The following is a description of a gene set: Any process that results in a change in state or activity of a cell or an organism (in terms of movement, secretion, enzyme production, gene expression, etc.) as a result of a stimulus arising within the organism. studied in species Homo sapiens Human Gene Set: GOBP_RESPONSE_TO_ENDOGENOUS_STIMULUS, and this is the list of marker genes: EEF2, CHRD, FGF6, GCLC, PLCG1, NDP, RB1, NPC1, CEBPA, UMODL1, ANG, GPLD1, LEPROTL1, FOXP1, BSG, FUT7, ABL1, GFRA1, DTYMK, RAP1A, SLC26A5, ADIPOR2, ACTA2, FGF17, PRKCQ, GHRHR, PKM, PTGFR, ZNF703, FRS2, SPART, FSTL5, FLRT1, LPL, XBP1, CYP11B1, RHOQ, NUDC, FASLG, RXFP1, BAIAP2, CDKN2B, TNFSF4, TMPRSS6, CSN1S1, BDNF, THRA, FGF3, EME1, SPRY3, CXCL12, GPX1, EMD, BCL9L, SCGB2A2, MIR302B, MIR342, EMILIN1, RUNX3, ATP5F1A, TACR1, SDCBP, PTF1A, CD44, FYN, PPARG, PML, DHRS3, XIAP, VWA2, HMGB1, GRIA1, CCR7, SYAP1, LHCGR, ADCY6 (NCBI Gene Id 23320), HMGA2, TMEM100, GLG1, GLP2R, FIBP, FAM89B, WNT1, TIGAR, FURIN, LTA4H, VEGFD, APOE, MYO5A, SOX2, CREB3L1, WNT7B, HIF1A, ABCC9, RCAN1, GRB14 (NCBI Gene Id 2888), ADCY8, GPER1, SMURF2, PRAME, CITED2, DOK5, LRRC32, MIR503, FGF20, MIR379, EGFR, FLT4, JUN, GBA1, PAK1, COMP, LIMS1, ROBO2, SP100, ADTRP, DEFA3, MED1, SNRNP70, MIR212, VEGFB, ACSBG1, AHSG, SLC2A10, CHRDL1, SPI1, RBM14, INTS9, ITGA2, SCN11A (NCBI Gene Id 337933), REST, UCN2, GCGR, DAND5, RAMP3, MIR143, SOCS3, RWDD1, EPM2AIP1, PROKR2, PTPN11, CDH5, AGRP, BMP5, SPINT1, INS, SUDS3, ADAMTS7, CSH1, PENK, THRB, CBL, IL1RN, AANAT, RGMA, OFD1, EDNRA, NR2F2, RNF111, PIP4K2A, ALPL, NCOA2, IDE (NCBI Gene Id 3416), RASL11B, ZEB2, CLDN4, KDM3A, CFL1, NR1H4, CALCR, EIF6, MIR4632, GDF9, ING1, KCNC1, FERMT1, MIR210, ILK, CCL19, WNT10B, ATF2, BCAR3, PTPRE, ADIPOQ, MIR498, CEP57, CD109, NFIA, ALAS1, NEFL, MIR424, GIT1, CSNK1E, KDM5B, FSTL1, TNC, ATP2B1, RAB31, OTC, ABCA2, ZDHHC17, INHBB, SAFB2, PITX3, MIR20A, GPR82, TRIM33, CRH, TPR, ASCL1, CTSH, SKI, TSC22D1, SH2B2 (NCBI Gene Id 10603), PCSK9, HMGB2, INPP5K, SLC4A7, RAP1GDS1, PDK4, TRIM71, PRL, CREBBP, HYAL2, HTRA4, LRG1, LRIT3, ANGPT1, BBS4, GNRH1, ZFHX3, TMF1, DDIT4, BMP4, ARRB2, SLIT2, FBP1, CCBE1, MIR10A, CSTF2, BMP7, MIR130A, AVPR1B, IQGAP1, F7, TGFB2, PRMT1, NRP2, FEZ1, UCN3, EXT2 (NCBI Gene Id 2132), DAB2, HDAC6, NR3C1, SLX4, MYOG, MIR1-1, FABP3, CORO1B, TRIM72 (tripartite motif containing 72), CEACAM1, PRLH, BCHE, BMP2, MAPK3, S100B, PIK3CA, RBM4, RBFOX2, AKT1, PIM1, GREB1L, TBX1 (NCBI Gene Id 7413), POSTN, CRHR1, VEPH1, TBC1D7, PPARA, CCNA2, SAP130, BECN1, SOCS7, WT1, SCAP, BRMS1L, MIR26A1, SLC5A5, SKOR2, VWC2, UBA5, AVPR1A, APP, IRS4, PADI2, JUNB, CCN1, HCRTR1, CACNA1H, SCNN1B, CELA2A, ARF6 (NCBI Gene Id 63379), MIR493, YWHAG, PIK3CD, FOXC1, GHR, GDF10, CYP11A1, HSP90AA1, KMT2A, PTGDR, OXT, CTNNA1, HGS, GIPC1, PHIP, NGLY1, HCN2, REG1B, IL22 (NCBI Gene Id 57328), CLOCK, MIR140, NR2C1, MIR204, GSK3A, PID1, MSX1, MIR9-1, HDAC2, PAK2, CREB1, SLC2A1, NPTN, MIR181A2, MIR142, ADGRG1, TBX20, MKKS (NCBI Gene Id 8195), PMEPA1, NR5A1, MSX2, ECHDC3, RARRES2, UGCG, FUZ, EGLN2, MIR372, GREM1, LCN2, LTBP3, MYC, GATA3, TGFBRAP1, NR4A3, ATP1A3, CLDN5, STAT5B, TMEM119, OVOL2, PTGER4, PHB1 (prohibitin 1), NRP1, KIDINS220, ACVR2A, ZNF366, CYP11B2, RAPGEF1, PIK3R2, GHRL, MIR10B, FKBP1C, SOX30 (SRY-box transcription factor 30), BMI1, STXBP4, FSHR, HDAC9, NOTCH2, MMP14, HPGD, SMAD4, CES1, NLK, TIMP2 (NCBI Gene Id 7077), OTX2, NGF, GABRB1, EZH2, NCK1 (NCK adaptor protein 1), PPARD, MIR497, NCOA5, ANXA1, SOS1, NPPA, DMD, ARID4B, SMC1A, ETV2, BMPR1A, USP9Y, DNAAF4, NR1H2, MT1G, SSTR2, RNF6, PRKCD, HSPA1A, FKBP8, NKX6-1, FNDC4, SFRP1, SPRY1, HAS1, RBX1, FUT8, TWSG1, NPNT, AREG, AKR1C1, ACVR1B, EXT1, CYBA, MIR103A1, MIR573, FST, RBP4, SOCS1, ROCK2, NFKBIZ, MIR23A, IGFBP7, ZNF8, SMAD1, SNCA, ENG, NCOA6, PARK7, CLDN1, EIF4EBP2, KRAS (KRAS proto-oncogene, GTPase), TIMP3, SULF2, PELO, ACVR1C, FLCN, PLA2G2A, USF1, GCLM, APOA1 (apolipoprotein A1), SOCS2, POR, NOS1, HCRTR2, FSHB, UBE2L3, ADAM17, RPS6KB2, IL23R (NCBI Gene Id 94006), NEDD4, PHOX2B, KLF15, NR2E3, FGF12, STMN2, CFLAR, ADIPOR1, EIF4A3, SORBS1, YY1, CYP27B1 (NCBI Gene Id 5135), EEF2K, STAT5A, CALR, DDR2, MIR27A, MIR106A, PDCD7, TLR6, CAT, DYNC1LI2 (dynein cytoplasmic 1 light intermediate chain 2), SREBF1, VWC2L, OGT, KDM1A, HRG, ZEB1, CUL3, ABCB1, CBX3, CRHBP, GATA5, NTRK3, PPM1A, EPRS1, HSPA8, LHX1, SHCBP1, PTPRJ, FGF9, BCAR1, MIR15A, LGMN, CRY1, LEMD3, GLP1R, ABCA3, SSTR1, JUND, ITGB6, MIR93, SLIT3, ANGPTL3, EDNRB, KMT2D, MUS81, APC (NCBI Gene Id 324), SSTR5, SLC2A4, LPIN2, HFE, TRIB3, FSTL3, MT-ND3 (NCBI Gene Id 4537), AKR1C2, MIR1298, CTSB, FAT1, ACVR2B, MIR520C, PLK5, UCN, TICAM1, LDLRAD4, REG3G, IL6, BRD8, GDF6, MIR208A, MIR758, FBH1, CXCL8, ALAD, FBXW8, YWHAH, PRKDC, GPR155, RAF1, TOMM70, FECH, MIRLET7B, PAQR7, CASK, NTF3, RERG, KAT2B, AHCYL1, PLN, ACR, ADRA1A, ITGB8, DLL1, GATA6, TMEM53, HOXA13, PLCB1, MXRA5, PRLR, DDRGK1, SOX11, BGLAP (bone gamma-carboxyglutamate protein), REG3A, SMAD5-AS1, FGF18, RAMP2, SLC2A8, SULF1, GALNT3, EHD4, LONP1, MC4R, STC2, SHC1, ARPC3, PTH, MBD5, ZFYVE9, STAT1, LATS2, EHD1, IL10, MIR98, GNAQ, DSG2, NPFFR2, PRKCI (NCBI Gene Id 5584), USP8, SMYD3 (NCBI Gene Id 81838), NCOA1, PER1, MIR100, CAV2, RARB, VASN, ERFE (NCBI Gene Id 151176), FLT1, HGF, FGF16, LEP, MDM2, TRIM24, RPS6KB1 (ribosomal protein S6 kinase B1), IDH1, NR1D2, PRKAA2, CCDC62, NEO1, FGF4, VDR, SHQ1, MIR29B1, RGCC, DDX5, UFM1, MIR339, GDF5, DAXX, QRFPR, LDLR, MYOCD, ASS1, TET1, FKRP, SRD5A1, EREG, URI1, CALCOCO1, NPAS4, AVPR2, SLC25A33, WDTC1, BTG2, NTF4, MIR199B, CTNNB1, OPRD1, CYFIP2, FAM20C, NR3C2, PAX9, VGF, HADHA, BLVRB, PAX8, ERBB2, TGFBR3, ZFP36L1, ZPR1, CPNE3, PXN, NOG, UBE2O, CAV1, UCP1, COL1A1, EIF2B1, CRY2, TCF7L2 (NCBI Gene Id 6934), IRS2, ANKRD13C, TRIM68, CRKL, MIR92A1, FLT3, ELAPOR2, UFSP2, TIMP4 (NCBI Gene Id 7079), PRKD2, PTPN2, PTPN1, POU5F1, MAP2K3, MMP2, AGTR1, NRROS, CLDN18 (NCBI Gene Id 51208), BCL9 (BCL9 transcription coactivator), NKX3-1, ITGB5, FGF5, CTSS, ABCA1, RAMP1, SRF, APAF1, NUS1, SCGB2A1, IL12B, ABCC8, TNF, INSRR, FKBP1A, FOXC2, BMP10, SOX5, SORL1, PNPLA3, PDE2A, ACACA, CD2AP, G6PC1 (glucose-6-phosphatase catalytic subunit 1), MAP2K1, HHEX, TRIM25, CNOT1, RXRA, FLRT2, USP15 (ubiquitin specific peptidase 15), SOX6, STK16, MIR199A1, TSPAN32, ZDHHC16, MAP2K5 (NCBI Gene Id 5607), CD24, FGF7 (NCBI Gene Id 82955), SRD5A2, NDEL1, EPHA8, HIVEP1, ZNF592, GH1, ASPN, RAN, MSTN, CDO1, PRKCG, NBL1, APPL1, PTPRU, TGIF1, SMAD6, IGFBP1, PHEX, FMOD, CCN2, ELK1, IL4, WFIKKN2, ATP1A2, CSRP3, SPRY2, TOB1, APPL2, RAP1GAP, IGF1R (NCBI Gene Id 51049), GNRHR2, HSF1, TGFB1, CTSL, RAB10, AGT (NCBI Gene Id 183), AGTR2, LRP6, ERN1, RAPGEF2, CXCL13, PTP4A3, PDGFRB, TADA3, CER1, KCNJ8, DLX1, DSTYK, TGFB3, PRCP, GPC1, TSC1, GTF2H1, PBLD, PROX1, ITGB1, RDX, VIL1, DLX3, TNXB, PDGFD, SNX5, IBSP, ASH2L, EDN1, PRMT2, AKR1C4, GRB2, LUM, FGF10, RAB35, PNPT1, DNAI1, MIR302A, SCNN1G, LANCL2, FERMT2 (FERM domain containing kindlin 2), GKAP1, SCX, GNAI1, SAP30, APLN, CGB3, PPP3CA, RELA, TCF12, STAT2, PTPRC, OXTR, SKOR1, NFE2L2, NKX2-1 (NK2 homeobox 1), VPS18 (VPS18 core subunit of CORVET and HOPS complexes), ZBED3, ERO1A, DENND4C, CIB1, BPTF, C2CD5, STC1, CYP24A1, AR, SOS2, CSF2RA, RXFP2 (NCBI Gene Id 122042), EPN2, IER2, GALP, NCOA3, SAP30L, SGCB, UBE2D1, CRHR2, ITGB2, ITGA3, MIR296, FGFBP3, HSPA1B, FHL2, RNF14, AKT2, PTK2, YAP1, PRDM14, FOXO4 (forkhead box O4), DDX17, VSTM2A, CITED4, TNFRSF11A, ZNF536, TMEM108, HTRA2, VPS13C, DUSP3, KDM4C, ASIP, OR51E2, SRC, GPI, KCNC2 (NCBI Gene Id 3747), NODAL, ARK2C, HIPK2, SLC34A2, SLC34A1, SP7 (Sp7 transcription factor), MIR361, TFAP4, ZFP36L2, PSG9, KCNQ1, CPEB2, TRIP4, ADISSP (NCBI Gene Id 54976), MIR195, HRAS, CTSD, NRXN1, SOST, SOX9, EGR1, DEFA1, JCAD, CCL21 (NCBI Gene Id 6366), MIR376C, GRB7, SLC27A1, DAB2IP, MEN1, TAC1, PCK2, PDGFB (NCBI Gene Id 5155), STEAP2, GPR22, SPRED2, FGF1, EEF1A1, MIR30B, SPRED3, TGFB1I1, HSPB1 (heat shock protein family B (small) member 1), ARPC1B, MIRLET7F1, TBC1D4, HTRA1, LEF1, MEF2C, CSH2, SCNN1D, INSR, WNT10A, GSTP1, BCAS3, PDE3B, UBE3A, EPB41L5, CTBP2, MIR323A, GRB10, FGF2, DUSP22, FGB, POU4F2, KHK, EIF2B3, GCNT1, GLB1, WFIKKN1, FBXL15, MIR373, CDC6, NFKB1, FOSL2, NOS2, ACVR1, MYO1C, RXRB, PPP2R5B, ZYX, LHB, JAK1, CD68, SFRP2, SKP2, NCL, FGFR1, MARS1, SFRP4 (NCBI Gene Id 6424), SEMA6A, FLRT3, CAV3, MYOD1, PDPK1, TSHR (NCBI Gene Id 7253), MEGF8, BLOC1S6 (biogenesis of lysosomal organelles complex 1 subunit 6), TAT, SNAI2, ESR2, ACTN4, MTCL2, HYAL1, BAMBI, NR5A2, GAS6, KNSTRN, AGTRAP, LRP5, OSTN, LTBP2, PDK2, ESRRA, IFT80, MIR196A1, FRS3, MIR490, DAG1, ARNT, NREP, SCGB1A1, COL1A2, GPR173, HES5, WNT5A, PROKR1, ADRA2A, SYK, MGARP, MYD88, TSKU, SOCS5, NR1H3, PIN1, EIF2B5, ACE, CHRDL2 (chordin like 2), NCOA4, SMARCC1, SIK2, UBR5, ESRRB, NOS3, SLC26A6, SELENOS (selenoprotein S), CNOT9, P2RY6, CRIPTO, TAF1, TRARG1, PPP1R9B, NTRK1, SLC27A4, LOX, MIR101-1, BRMS1, HAS2, PALS1, PIK3R3, LATS1, SHOC2, TMEM107, GNAS, AXIN1, SPRED1, BMAL1, SRSF4, PELP1, ZBTB7A, NDN, KAT2A, POMC, SHISA2, ERRFI1, AKAP8, CASR, PRKD1, CORO1A, MIR19B1, TCF21, BMPR2, DLL4, DKK1, GAB1, HIF1AN, ALDH1A2, MEIS2, ZDHHC7, LRP2, DUSP6, ERBB4, PLA2G1B, KLF2, MAPK7, SGK1, INHBA, ADAM9 (ADAM metallopeptidase domain 9), CPEB1, ACAT1, PIAS2, NR4A1, RUNX2, FGFRL1, PIP4K2B, AKT1S1, AKR1C3, SREBF2, RACK1, MAP1B, DSG1, CARD9, FER, GPHB5, CHUK, RARG, NSMF, SLC39A14, TRIM63, SOSTDC1, GCG, HADH, CCL2, BMP6, ID1, IGF2, LMO3, NGFR, PKD1L1, TGFBR3L, PRKCZ, FFAR3, LYN, RBPJ (NCBI Gene Id 51580), RHOXF1, MEAK7, RAB14, PDGFRA, KDM5D, SMAD3, NTRK2, ACTN2, EPO, FUT1, WBP2, GNB1, IL1B (NCBI Gene Id 3553), PKLR, SAFB, UFL1, STRAP, MT3, RXRG (NCBI Gene Id 6258), DNM3OS, GSK3B, FOXO1, MTSS2, IGFBP5, LEPR, CRIM1, ACVRL1, CRB2, MAPKAPK2, MIR4286, STRN3, MDK, SLC24A4, FBN2, MIR19A, PDE8A, EP300 (NCBI Gene Id 2033), RBBP4, OCSTAMP, GCK (NCBI Gene Id 2645), PKD2, ARID5A, GNG2, LCN8, GOT1 (NCBI Gene Id 2805), SPINT2, CASP3, USO1, ISL1, PTPRK, PDX1, INSIG2, EIF2B2 (NCBI Gene Id 8892), SPG21, FGF14, TMEM204, CCND1 (NCBI Gene Id 893), AIFM1, MIR125B1, RAB8A, RAC1, FBN1, ING2, INPPL1, MIA3, CAB39, CDH3, BCL2, ZNF106, CD63, FGF23, SNX6, TFF1, ETNPPL, KRT19, ESRRG, WNT4, SPP1, CYC1, ASXL1, NUMA1, OXCT1, PHB2, SINHCAF, GPRIN3, KANK2, FGF22, MT-CYB, SIN3A, CD9, HSD11B2, CYP26C1, ROCK1, DDIT3, JAK2, XCL1, ZNF423, CNOT2, BBS2, STUB1, TSPO, MIR1271, FOS, USP9X, FAM114A1, ZFYVE27, SMAD9, FAM107A, HCLS1, SOX10, GAL, FGF8, SKIL, DHCR24 (24-dehydrocholesterol reductase), ZMIZ2, ADAMTS3, NOTCH1, GDF7, RETN, MMRN1, FCER1G, EPHA2, LRP8, GNRHR, PLPP1, MTOR, MIR302C, ACAP2, MAPK14, PTPN12, GHSR, HEYL, PDCD4, MTMR4, PCSK6, VAMP2, CSNK2B, HHIP, SCNN1A, ABHD2, SNX25, PKN1, MIR885, HDAC5, CYP26A1, MAP3K7, NKX2-2, KLB, EGR3, NDST1, KCP, NONO, SNW1, ATP2B4, TWF2, FOSB, CHST11, UCP3, HJV, PTGER1, ZNF764, ITGA8, GPR150, MIR329-1, CILP, CGA, AGL, TNS2, ME1, FGFR4, CPN1, GATA4, LEPROT (NCBI Gene Id 83080), HAP1, FOXA1, MIRLET7A1, FZD1, TOP1, NDNF, PIP4K2C, FNTA, SH3GL2, CACNA2D3, CSHL1, MN1, LPXN, E2F1, MZB1, SMPD3, SSTR3, PRDM16, SFR1, MME, ADAMTS12, FGF21, CREBRF, EIF2B4, SP1, STK39, MIR107, OTOP1 (NCBI Gene Id 133060), TRIM16, CAPN10, SMAD5, KBTBD2, SPHK1, OPRK1, DOCK3, TFPI, REG1A, CD38, GDF2, CPS1, TIMP1, DEFA1B, RANGAP1, COL4A2, BMPR1B, GAREM1, FGFBP1, CRK, DKK3, NR0B1, CHURC1, PIK3R1, FOXH1, CYP26B1 (NCBI Gene Id 56603), CADM4, CUL7, GDF3, PRKCB (NCBI Gene Id 5579), NR2E1, BAG4, HNRNPU, CA2, PRKN, DUSP1, WNT7A (Wnt family member 7A), ADAMTSL2, IGF1, PDCD5, ZFP36, ESR1, REN, SERPINB9, KDR, STXBP3, DDX54, MAPT, IL17F (interleukin 17F), BCL2L11 (NCBI Gene Id 150819), EFNA5, TRERF1, HSP90AB1, ACOD1, P2RY1, CD36, LEFTY1, SRSF5, ZNF451, NPFFR1, TP63, MAPKAP1, PRKCE, GCNT2, TXNIP, FGF19, RGMB, MIR183, THBS1, SLC22A12, RHOA, PTGER2, PTGDS, PRKAA1, IL12A, PDE3A, MMRN2 (NCBI Gene Id 79812), VPS11, BTG1, ENPP1 (ectonucleotide pyrophosphatase/phosphodiesterase 1), PTGDR2, TFAP2B, MIR145 (NCBI Gene Id 406937), PGF (placental growth factor), AMHR2, ONECUT2, C1QTNF12, MIR17, NR1D1, YES1, NUCKS1, HPN, GPR83, VEGFA, TGFBR1, MIR200C, CYP7B1, SORT1 (sortilin 1), HDAC1, CARM1, CTDSPL2, SCUBE3, WNT2, MAS1, PCNA, SLC30A10, PCK1, GKN2, CITED1, IGFBP2, CST11, FZD4 (NCBI Gene Id 8322), SLC39A5, STAT3, KLF9, AQP1, TBX2, NCOR2, KL, ITGB1BP1, MIR27B, NPR2, FGFR2, TREM2, PEG10, CDK12, LTBP1, FAM83G, SMURF1, ONECUT1, EIF4E, AP3S1, GDF15 (NCBI Gene Id 9518), GATA1, STAT6, MIR149, RIPK1, STAT4, OSBPL8, RAB13, ANGPT2, UPRT, PRKACA (NCBI Gene Id 5566), SPRY4, MIR1224, ACSL1, RARA, FOXO3, COL6A1, LCAT, MICOS10-NBL1, SH3RF1, KLF4, MIR15B, SIRT1, FBXW7-AS1, CALCA, VCAM1, GAS1 (growth arrest specific 1), RHOD, FBXO32, RPS6, CAMK2A, METTL21C, SLC12A3, MIR135A1, EID2, CDKN1C, ZMIZ1, GH2, USP26, INSIG1, LTBP4, PAQR8, COL3A1, PPP5C, FSTL4, UCP2, SLC10A1 (NCBI Gene Id 6554), HTRA3, PRKAR1A, TRPV4, COMT, ARSB, MIR146A, UBE2D3, MIR564 (microRNA 564), SMAD7, ZBTB7B, ATP1A1, P2RY4, DSG4, TGFBR2, WWOX, TSC2, KANK1, HOXA11, CALM3, MIR16-1, CYBB, JAK3, CASP9, FGFR3, CCKAR, CD81 (CD81 molecule), SESN3, NCOR1, TNFAIP6, CIDEA, PRKCA, HDAC3, STK11, TYK2, ARID4A, CYFIP1, CDH13, SESN2, WASF1, ZMPSTE24, CCL5, AXIN2, MECOM, GREM2, MAPK1, PIK3CB, SMAD2, HSPA5, RBPMS2, SRARP (NCBI Gene Id 149563), SELENON (NCBI Gene Id 7800), PGR, GSTM3, HNF4A, SERPINA12, IRS1, VEGFC, SSTR4, PARP1, NAMPT, CAD, NR4A2 (nuclear receptor subfamily 4 group A member 2), MCM7, HOXA10, GPR21, SLC9A1, MSI1, HMGCS2, MAGI2, FOLR1, VTN, CSK, DCN, TP53, SST, PAGR1, PIK3C2A, RBBP5, CACYBP, GPC3, ROBO1, DLX5, MIR30A, SMOC2, MIR214, DHH, BMPER, ADGRA2, CBLC, HES1, KIF16B, TAB1, FOXD1, C2, SMARCA4, LPIN1, COL2A1, BRCA1, PDCD6, TLR4, MIRLET7G, ITGB3, MMP19, RBBP7, SRSF6, TAF7, MIR21, FKBP4, LPIN3, IL17RD, VPS54, ITGA5, SERPINF1, PPARGC1B, ANKRD1, MIR18A, LBH, PGRMC2, TRH